The following is a description of a gene set: The change in morphology and behavior of a monocyte resulting from exposure to a cytokine, chemokine, cellular ligand, or soluble factor. Human Gene Set: GOBP_MONOCYTE_ACTIVATION studied in species Homo sapiens, and this is the list of marker genes: LILRB4, NPY, HYAL2, DYSF, CD33, CSF1, MT1G, FOXP1, ADAM10, SPACA3, ADAM9, FN1, AZU1